The following is a description of a gene set: RMTs methylate histone arginines Human Gene Set: REACTOME_RMTS_METHYLATE_HISTONE_ARGININES species: Homo sapiens, and this is the list of marker genes: H4C12, H3C6, H2AC8 (NCBI Gene Id 3012), H2AC14 (H2A clustered histone 14), SMARCD1, SMARCB1, H2AC17, WDR77, H3C10, H3C2, H2AC16 (NCBI Gene Id 8332), CARM1, PRMT7, SMARCE1, H2AC15, H2AC20, COPRS, H2AB1, H4C14, H4C2, SMARCD2, H4C3, SMARCC2, H3C7, H2AJ, ARID1B, RPS2, H3C13, H3C8, H4C4, H4C15, H2AC11, H4C8, H2AC12, SMARCD3, H4C1, H2AC25, WDR5, H3C14, PRMT1, H4C9, DNMT3A, H3C1, SMARCC1, H4C11, H4C5, PRMT5, H2AC4, ARID1A, CCND1, H4C16 (H4 histone 16), H2AC18, H2AC1, PBRM1, RBBP7, H2AC13, CDK4, ACTL6B, H4C13, H3C15, H2AX, H2AC7, H2AZ2, H2AC21, SMARCA2, PRMT6, ACTL6A, H2AC6, JAK2, H2AC19, H3C3, SMARCA4, H3C4, PRMT3, H3C12, H4C6, H3C11, ARID2